The following is a description of a gene set: studied in species Mus musculus Genes predicted to be targets of miRBase v22 microRNA mmu_miR_5119 in miRDB v6.0 with MirTarget v4 prediction scores > 80 (high confidence targets). Mouse Gene Set: MIR_5119 from publication Chen Y, Wang X (PMID 31504780), and this is the list of marker genes: Opn4, Trabd2b, Scn7a, Smoc2, Esp24, Dlgap2, Arhgap18, Dtymk, Psg22 (NCBI Gene Id 243862), Sytl5, Trdn, Potefam3a, Nsun6, 1700066M21Rik, Tmem184b, Gabrg1, Cebpd (CCAAT/enhancer binding protein delta), Zkscan2, Zfp282, Bpnt2, Dcdc2c, Trip10, Ssbp1, Dner (delta/notch-like EGF repeat containing), Nphs1, Tmem161b, Osbpl11, Nhsl2, Tmem218, Efhd2, Apln, Car8, Hdac1, Lmx1a, Timm9, Sgo2a, Trpc5, Frs2, Zfp52, Potefam3b, Aknad1, Mob4, Ttc9, Rfx7, Camk4, Ankrd17, Mmrn1, Gpr12, Pask, Chd9, Oxgr1, Tet2, Tpbpa, Fgfr1op2, 1700017N19Rik, Bag3, Vmn1r45, Ankzf1, Pde1a (phosphodiesterase 1A, calmodulin-dependent), Acbd5, Epyc, Krtap26-1, Trpm3, Potefam3e, Tmem167 (NCBI Gene Id 77129), Mzt1